Given this list of marker genes Gm7936, Gm41780, Gfra3, Gm25396, Gm26533, Polr2d, Srp19, Brd8dc, Tslp, Syt4, Gm22200, Wdr33, Gm6665, Wnt8a, Gm50060, Nrep, Map3k2, Ammecr1l, Gm5503, Bin1, Egr1, Gm7917, Cdc25c, Gm7941, Gm22788, Rpl27rt, Rit2, Epb41l4a, Slc25a46, Gm6724, Gm3587, Fam53c, Gm50265, Cdc23, Gm36037, Gm24432, Proc, 2010110K18Rik, Gm5241 (predicted gene 5241, NCBI Gene Id 383420), Gm7926 (predicted gene 7926), Gm26109, Epb41l4aos, Gm23639, Kif20a, Hspa9, Ctnna1, Fam13b, Etf1, Gm26717, Wdr36, Reep5, Gm16344, Mir6361, B930094E09Rik, Apc, Gm5969, Gm20136, Ercc3, Lrrtm2, Gm44577, Gm6052, Gpr17 (G protein-coupled receptor 17), Rpl29-ps5, Gm7930, Gm10549, Gypc, Brd8, A830052D11Rik, n-R5s25, Pik3c3, Gm10548, Stard4, Myo7b, Lims2, Kdm3b, Gm22870, Gm25826, Tex51, Pkd2l2 (polycystic kidney disease 2-like 2), 2310026I22Rik, Iws1, Camk4, Gm5238, Nme5, 4933435E02Rik, Sap130, Reep2, Sft2d3, here is a description of the gene set: Mouse Gene Set: chr18B1 species: Mus musculus